Given this list of marker genes Gm34217, Gm36866, Gm28089, Gm21065 (predicted gene, 21065), Gm20865, Gm28938, Gm21679, Gm28326, Gm29401, Gm20810, Gm28489, Gm28780, Gm28247, Gm30175, Gm28295, Gm31123, Gm21771, Gm21845, Gm21821, Gm36468, Gm29866, Gm20893, Gm28245, Gm31422, Gm21804, Gm21427, Gm21753, Gm21506, Gm35955, Gm21488, Gm21907, Gm28090, Gm30598, Gm21853, Gm21366, Gm28127, Gm28936, Gm28244, Gm29581, Gm36047, Gm28093, Gm29369, Gm20857, Gm21469, Gm31335, Gm32180, Gm29582, Gm21768, Gm21094, Gm21890, Gm21661, Gm20926, Gm29317, Gm21737, Gm21744 (predicted gene, 21744), Gm21539, Gm33163, Gm28486, Gm20809, Gm21572, Gm20858, Gm20890, Gm31571, Gm28249, Gm36345, Gm21412, Gm34274, Gm28454, Gm20895, Gm28298, Gm28987, Gm20892, Gm28296, Gm20909, Gm21642, Gm20925, Gm28091, Gm21871, Gm21529, Gm21476, Gm33954, Gm20811, Gm32347, Gm28243, Gm28216, Gm21443, Gm20910, Gm20891, Gm30705, Gm20894, Gm21842, Gm21908, Gm29740, Gm21791, Gm21562, Gm32114, Gm29399, Gm28248, Gm20840, Gm28092, Gm35670, Gm28764, Gm30858, Gm28130, Gm33571, Gm31572 (predicted gene, 31572), Gm32181, Gm28879, Gm21350, Gm36891, Gm29316, Gm30045, Gm21755, here is a description of the gene set: studied in species Mus musculus Mouse Gene Set: chrYA2